The following is a description of a gene set: studied in species Mus musculus Mouse Gene Set: chr2H3, and this is the list of marker genes: Mir7004, Svs6, Rbm38, Kcng1, Ptpn1, Gm14237, Pmepa1, E130018N17Rik, Gm14273, Sulf2, Dok5, Rae1, Gm11457, Gm25512, Ppp4r1l-ps, Gm11471, Wfdc2, Wfdc15b, Ncoa3, Bcas1os1, Sys1, Gm14269, Rab22a, 5031425F14Rik, Zfp334, Spo11, Gm14320, Dpm1, 9230111E07Rik, Acot8, Adnp, 1110018N20Rik (NCBI Gene Id 68941), Slc35c2, Neurl2, Gm14437 (NCBI Gene Id 102631658), R3hdml, Gm20716, Ccn5, Fam210b, Elmo2, Kcnk15, 9430093N23Rik, Wfdc13, Ptgis, Spint5, Zbp1, Wfdc5, Slpi, Gm14455, Snai1, Cse1l, A530013C23Rik, Fitm2, 0610039K10Rik, Tfap2c, Zswim1, Cd40, Gm14637, Gm14270, Wfdc16, Semg1, Gm14319, Pabpc1l, 1700025C18Rik, Gm25878, Slc13a3, Ankrd60 (ankyrin repeat domain 60), Sdc4, Zfp663, Gm11470, Tomm34, Wfdc3, Gm14453, Spata25, Ncoa5, Ywhab, Gm11456, Spint4 (serine protease inhibitor, Kunitz type 4), Zfp217, Rnf114, Gm14267, Ctsa, Stau1, Eya2, Ada, Atp9a, Bmp7, Gm11462, 2310001K24Rik, BC046401 (cDNA sequence BC046401), Jph2, Gm14234, Fam209, Gm11476, Svs5, Ddx27, Wfdc9, Gm14317, Aurka, Zfp335, Trp53tg5, Gm14642, Znfx1, Ripor3, Gm16796, A730032A03Rik, Matn4, 2900093K20Rik, Mir7678, Prex1, Cstf1, Zfp64, Gm25569, Ube2c, Gm25214, Wfdc11, Peds1, Snord12, Gm14261, Kcns1, Eppin, Spata2, Sall4, Trp53rka, Wfdc10, Gm23201, Zfp335os, Stk4, Kcnb1, Gm14263, Cimip1, Ttpal, Gm11474 (NCBI Gene Id 100502654), Slc9a8, Slc2a10, Oser1, Pfdn4, Tnnc2, Mmp9, Cdh22, 1700028P15Rik, Gm14264, Cass4, Gm25881, Tshz2, Gm14274, Ctcflos (NCBI Gene Id 74161), Nfatc2, Slc12a5, Gm9873, Wfdc15a (WAP four-disulfide core domain 15A), Zfas1, Pigt, Cyp24a1, Ctcfl, Bcas1os2, Wfdc12, AY702102, Gm26489, Gm22704, Gm14275, Mocs3, Bcas1, Gm14250, Pcif1, Pmepa1os, Gm11466, Spint3 (serine peptidase inhibitor, Kunitz type, 3), Trp53rkb, Pkig, Snx21, Gm11465, Zswim3, Gdap1l1, B4galt5, Gm14249, Wfdc8, Platr29, Ube2v1, Svs3b, Gm34294, Mc3r, Serinc3, Wfdc6a, Pard6b, Gm11472, 4930470P17Rik, Rbpjl, Gm11473, Zmynd8, Arfgef2, Pck1, Svs4, Hnf4aos, Svs3a, Hnf4a, Cebpb, Gm11475, Dnttip1, Dbndd2, Gm16316, 4930529I22Rik, Pltp, 1700017J07Rik, Gcnt7, Ocstamp, Cbln4, Gm24473, Gm14303, Rtf2, Gm14268, 1200007C13Rik, Rims4, Gm11468, Wfdc6b